Given this list of marker genes NYNRIN, PLK4, INSM1, LRP8, ANKRD2, CAV2, FADD, AKIP1, VPS54, GINM1, MAPKAPK2, LRRC59, NPLOC4, ZBP1, TEK, PRRC1, MYO1B, TOM1L1, CHDH, GBE1, BCL7C, KATNBL1, F3, IFNB1 (NCBI Gene Id 3456), HOXA9, B4GALT3, ATP6V1E1, MORC3, INSR, HOXA13, UBE2S, TM4SF1, FGL2, RRP7A, CLRN3, GTF2E2, PARP14, GPR137B, IER5, PMPCA, SLC33A1, GIPC2, TNRC6A, TPBG, CUTC (NCBI Gene Id 51076), ADH7, PPIC, TP53RK, HOXB3, AGRN, CCL11, WSB2, GTPBP2, KCNS2, SENP1, STK40, KRT2, PLEKHA2, RAP2A, YAE1, SQSTM1, FUT7, PPP2R5A, DDA1, GPR3, VPREB3, EEF1E1, RNF214, IFT172, GK, PLAGL2, DENND2B, STXBP3, PSMA2, EEA1, COL9A1, PTGR3, PRPF38A (pre-mRNA processing factor 38A), LMO4, KCNN4, IGBP1, LHX2, MED28, GRAMD1A, CTCF, LYPD3, APPBP2, GAPDHS, POLB, P2RX1, MTFR2, ARID5B, CCNL1, RASA2, RCSD1, DNAJB11, GBP2, PXK, POP7, BRAF, BST2, CCL2, KCNQ5, UBE2M, NMD3, NOTCH3, CNP, POFUT1, KAT2B, RALGDS (ral guanine nucleotide dissociation stimulator), ARFRP1, CHMP3, NR1H3, INTS6, UBXN11, KDM5D, SAMSN1, BCL2L1, CAPN5, HK2, ADAMTSL5 (NCBI Gene Id 339366), CMTR1, NRAP, CYP1B1, PDZK1IP1, CRYBB1, CDH3, DACH1, PRMT6, PPIG, STAG1, MTHFD2, MARCHF7, LHX6, MTDH, NAB1, MYLIP, MMP2, TMEM39A, TAGLN2, PPT2, YRDC, REXO4, TTC39C, RGS20 (regulator of G protein signaling 20), ABR, EMC2, HOXA3, TOP1, GBP6, RIPK2, YARS1, SLC26A1, ETF1, IGSF9, RIMKLB, M1AP, GOSR1, GABARAPL2, RAB30, KLHL13, CACNA1A, PLSCR1, SLC5A5, STARD5, SPARC, CD79B, NFKBIA, DUSP16, RBM47, ELOC, SLC6A13, MTF2, SALL4, ALOX12, CACNG3, DDHD1, CAV1, ADORA1, CA14, CXCL9, SLAMF6, ENG, MITD1 (NCBI Gene Id 129531), RUNX2, PTGES, CPEB1, HCAR2 (NCBI Gene Id 338442), CHD1, LAP3, CLK3, C18orf21, HDAC1, DNAJB1, TXK, TSPYL1, MTMR7, GJA10, CNOT7, MAN2A1, here is a description of the gene set: mouse primary BMDCs were stimulated with tlr ligands and gene expression changes were profiled on Affymetrix arrays Genes down-regulated in comparison of control dendritic cells (DC) at 8 h versus those stimulated with CpG DNA (TLR9 agonist) at 8 h. studied in species Homo sapiens from publication Amit I, Garber M, Chevrier N, Leite AP, Donner Y, Eisenhaure T, Guttman M, Grenier JK, Li W, Zuk O, Schubert LA, Birditt B, Shay T, Goren A, Zhang X, Smith Z, Deering R, McDonald RC, Cabili M, Bernstein BE, Rinn JL, Meissner A, Root DE, Hacohen N, Regev A (PMID 19729616) Human Gene Set: GSE17721_CTRL_VS_CPG_8H_BMDC_DN